The following is a description of a gene set: from publication Tien MT, Girardin SE, Regnault B, Le Bourhis L, Dillies MA, Coppée JY, Bourdet-Sicard R, Sansonetti PJ, Pédron T (PMID 16394013) species: Homo sapiens Shigella invades the human intestinal mucosa, thus causing bacillary dysentery, an acute recto-colitis responsible for lethal complications, mostly in infants and toddlers. Conversely, commensal bacteria live in a mutualistic relationship with the intestinal mucosa that is characterized by homeostatic control of innate responses, thereby contributing to tolerance to the flora. Cross-talk established between commensals and the intestinal epithelium mediate this active process, the mechanisms of which remain largely uncharacterized. Probiotics such as Lactobacillus casei belong to a subclass of these commensals that modulate mucosal innate responses and possibly display anti-inflammatory properties. We analyzed whether L. casei could attenuate the pro-inflammatory signaling induced by Shigella flexneri after invasion of the epithelial lining. Cultured epithelial cells were infected with L. casei, followed by a challenge with S. flexneri. Using macroarray DNA chips, we observed that L. casei down-regulated the transcription of a number of genes encoding pro-inflammatory effectors such as cytokines and chemokines and adherence molecules induced by invasive S. flexneri. This resulted in an anti-inflammatory effect that appeared mediated by the inhibition of the NF-kappaB pathway, particularly through stabilization of I-kappaBalpha. In a time-course experiment using GeneChip hybridization analysis, the expression of many genes involved in ubiquitination and proteasome processes were modulated during L. casei treatment. Thus, L. casei has developed a sophisticated means to maintain intestinal homeostasis through a process that involves manipulation of the ubiquitin/proteasome pathway upstream of I-kappaBalpha. Genes down-regulated in Caco-2 cells (intestinal epithelium) after coculture with the probiotic bacteria L. casei for 24h. Human Gene Set: TIEN_INTESTINE_PROBIOTICS_24HR_DN, and this is the list of marker genes: TES, GOT1, ARF4, RPS3, MCTP2, MAN2B1, ACTG1, UBXN4, NAP1L1, PRSS3, VEGFA, EEF1G, ADNP2, SEL1L, RPS19, SARS1, SLC35E1, RPS18, RPS27, STX5, ELF3, HSPA9, FTL, MTHFD2 (NCBI Gene Id 10797), MSTO1, TTC3, MTA1, TRIB3, ZMYM4, ALDH3B1, DTX2P1-UPK3BP1-PMS2P11, PPIB, MARCHF5, HSPA8, RPLP0, FICD, RPL13A, CD55, SEC63, VASP, NFIL3, TMCO3, RPL39, JAG1, PCK2 (NCBI Gene Id 5106), TRAM1, AFTPH, HYOU1 (NCBI Gene Id 10525), RPS24, AUH, RPS23 (NCBI Gene Id 6228), MTDH, RAB2A, SLC1A5, RPL5, RPL27A, UBE2H, KLHL24, FTH1P5, CLCN3, GLRX, TFG, TANK, SLC1A4 (solute carrier family 1 member 4), PRR15L, AGR2, ARMCX3, RPS14, LARP6, SQSTM1, SAT1, CALR, THOC2, RPL23A, ZNF282, BTG1, SLC6A8, PTPRF (protein tyrosine phosphatase receptor type F), UNC5B, HERPUD1, HSP90B1, HSPH1, ZNF236, ESRP1, CSNK1A1, DDIT4, GCNT3, ACBD3, PABPC1, PDIA3, SLC43A1, SEL1L3, SERP1, KAT6B, ARHGEF2, GFPT1, RARA (NCBI Gene Id 5914), TCEA1, GATAD1, WIPI1, SLC7A1, KLF5, CREB1, RPS6, NUCB2, CEBPB, PPP1R15A, CANX, AKR1B10, RPS11, RPL41, EPHB4, RPL9P7, HOOK1, RPS2, GDF15, CTAGE9 (CTAGE family member 9), TFE3, NDRG1, RPL37A, P4HB, ARIH1, EIF1, GCLM, RMND5B, NUDT4, LAMP3, RNF19B, AKR1C1, TTC17, EEF1A1, NCOR1, FAF2, FNDC3A, ATL2 (NCBI Gene Id 64225), HKDC1, SNHG32, GARS1, PNRC1, TMEM39A, EEF2, INHBE, RPL3, CBX4, MLPH, KDELR1, RPL23, MBNL2, ZNF277, RPS3A, MAN1A2, NQO1, RPS7, MIA3, TBC1D15, ARHGAP35, CEP57, AARS1, TMED5, TMED2, TPT1, GOLGA5, CDC6, ATF2, RPL4, RPL34, PJA2, COG5 (NCBI Gene Id 10466), RPL13, MAP2K2, CDC5L, H1-0, UBC, PRNP, TSPAN31, RANBP9, CEBPG, HSPA5, LRRFIP1, RACK1, RPL12, IFRD1, PDIA4, SLC3A2, TMED7, TXNRD1, MTFR1, UGT1A10, NBR1, EIF5A (eukaryotic translation initiation factor 5A), CDK2AP2, DNAJB9, S100P, SGSM3, ATF3, PDCD4 (programmed cell death 4), ASNS, EIF4B, DNAJC10 (NCBI Gene Id 54431), SH3GLB1, MANF, LAMB3, SDF2L1, ST6GALNAC4, GRB10, PLAAT4, FTH1, HSPA13, PDE8A, WARS1, LPIN2, PDIA6, BNIP3L, FAM120A, WDR45